The following is a description of a gene set: studied in species Mus musculus Mouse Gene Set: GOBP_GLIAL_CELL_DEVELOPMENT The process aimed at the progression of a glial cell over time, from initial commitment of the cell to a specific fate, to the fully functional differentiated cell., and this is the list of marker genes: Gpm6b, Pi4ka, Lamc3, Dll1, Pten, Il1b, Drd1 (dopamine receptor D1), Pard3, Ano1, Grb2, Lgi4, Raf1, Phgdh, Ccdc39, Kcnj10, Ilk, Eif2b5, Kras, Vim, Tlr4, Nf1, Map2k2, Slc25a46 (NCBI Gene Id 67453), Nrg1 (neuregulin 1), Arhgef10, Ercc2, Nr1d1, 9630013A20Rik, Hdac11, Ager, Dicer1, Pou3f1, Lrp1, Nkx6-2, Ror2, Tlr2, Ascl1, Gfap, Pou3f2, Tcf7l2, Dmd (dystrophin, muscular dystrophy), Aspa, Ncstn, Akt1, Sox11, Erbb3, Med12, Cdk5, Prdm8, Sox4, Eif2b3, Ldlr, Omg, Naglu, Abca2, Hes5, Mobp, Sos1, Ckap5, Nfix, Nrros, Ncmap, Enpp1, S100a9, B4galt5, Cntnap2, Adora2a, Agt, Tenm4, Ski, Mecp2, Mdk, Adam22 (a disintegrin and metallopeptidase domain 22), Plp1, Egfr, Tspan2, Itgb4, Pals1, Id2, Cntn2, Itgam, Mapk3, Gm5849, Pick1, Cntf, Myoc, Akt2, Pdgfb, Mag, Nsun5, Adgrg6, App, Id4, Dag1, Erbb2, Grn, S100a8, Nkx2-2, Shh, Plec, Ppp3r1, Mapk1, Psen1, Hras, Ntrk2 (NCBI Gene Id 77471), Ifngr1 (NCBI Gene Id 15979), Cntn1, Mios, Zfp488, Ulk4, Smo, Ifng, Wasf3, Lyn, Olig1, Fgfr3, Trem2, C1qa, Col6a1, Tppp, Eif2b1, Ndrg1, Sox10, Sirt2, Zeb2, Cspg5, Ntrk3, Dhh, Mal, Tgfb1, Lpar1, Lamb2, Ror1, Clu, Pmp22, Eif2b4, Mxra8, Eif2b2, Sh3tc2, Csf1r, Sod1, Fa2h, Myrf, Cntnap1, C5ar1, Prx, Gstp1, B4galt6, Map2k1